Given this list of marker genes B4GALT6, RAB14, TUBA4A, FHOD1, CREB3L1, ERGIC2, GLRX, TIMP3, SRSF6, DNAJB4, GRB10, GOLIM4, EIF5A, PPP3CA, POM121, ATP1A2, SLC7A1, LEPROT, GFPT2, SRP72, RAB40B, SIRPA, PEG3, EMP1, SEL1L, MKNK2, FGF1, EREG, SNAI2, PHLDA2, NBL1, PRKCD, DARS1, RBM8A, TBC1D2, ACTN1, SLC20A1, HMGA1, IL4R, ADM, PLEC, AHCYL1, RLF, ULBP2, PLXND1, CX3CL1, CSPG4, PDE10A, BAIAP2, IL1RAP, MARK4, PLEKHO1, CHST3, TPST2, HBEGF, RYBP, SPEN, IL11, PA2G4, SLC35G2, SPHK1, SERPINH1, DLX2, ZMIZ1, PDLIM4, PIAS2, LYN, SON, RSL1D1, RIPOR1, PIK3CD, HSPA6, PIM1, SNAP23, TPBG, JUN, KHSRP, TNS1, ENO2 (enolase 2), PLAUR, ZMYM6 (zinc finger MYM-type containing 6), GEM, NLK, RGS4, DUSP7, PCDH7, SWAP70, TM4SF1, NAA15, SPRED2, RHOF, ST3GAL1, SYNJ2, PEA15, HNRNPUL1, MTMR1, DNAJB1, WSB1, HSPA1B, KPNA6, HSPA1A, ARHGDIA, HSPH1, AREG, CA12, TRIB1, SERTAD2 (NCBI Gene Id 9792, SERTA domain containing 2), SYNE1, DOK5, MAP2K3, RHOQ, PURA, CSDC2, PTHLH, SET (NCBI Gene Id 6418), HSP90AA1, IVNS1ABP, BMPR2, SERPINE1, PDGFC, DICER1, MAFF, CARM1, ATP2B1, RGPD5, FGFR1, SOX9, WWP1, ATP9A, WT1, STRN4, DOK4 (NCBI Gene Id 55715), FOSL1, GTPBP1, HIPK1, ARC, DPEP3, QKI, PODXL (NCBI Gene Id 5420), HNRNPL, SUPT6H, TOP1, SH3BP5, KLF10, JUNB, WWTR1, TGFB1I1 (NCBI Gene Id 94988), ADAM19, DAB2, DNAJB5, ABHD3 (NCBI Gene Id 90492), IL6ST, ZYX, BCL2A1, CBFB, LAMB3, METAP2, AFF1, ID4, BTG3, MICALL1, NPIPB3, ZC3HAV1, CDR2L, SFN, ABAT, CSF1, here is a description of the gene set: Genes up-regulated in UB27 cells (osteosarcoma) at 8 hr after inducing the expression of a mutant form of WT1. Human Gene Set: KIM_WT1_TARGETS_8HR_UP The Wilms' tumor suppressor gene (WT1) encodes a zinc finger transcription factor that is vital during development of several organs including metanephric kidneys. Despite the critical regulatory role of WT1, the pathways and mechanisms by which WT1 orchestrates development remain elusive. To identify WT1 target genes, we performed a genome-wide expression profiling analysis in cells expressing inducible WT1. We identified a number of direct WT1 target genes, including the epidermal growth factor (EGF)-family ligands epiregulin and HB-EGF, the chemokine CX3CL1, and the transcription factors SLUG and JUNB. The target genes were validated using quantitative reverse transcriptase-polymerase chain reaction, small interfering RNA knockdowns, chromatin immunoprecipitation, and luciferase reporter analyses. Immunohistochemistry of fetal kidneys confirmed that a number of the WT1 target genes had overlapping expression patterns with the highly restricted spatiotemporal expression of WT1. Finally, using an in vitro embryonic kidney culture assay, we found that the addition of recombinant epiregulin, amphiregulin, CX3CL1, and interleukin-11 significantly enhanced ureteric bud branching morphogenesis. Our genome-wide screen implicates WT1 in the transcriptional regulation of the EGF-family of growth factors as well as the CX3CL1 chemokine during nephrogenesis. from publication Kim HS, Kim MS, Hancock AL, Harper JC, Park JY, Poy G, Perantoni AO, Cam M, Malik K, Lee SB (PMID 17430890) species: Homo sapiens